Given this list of marker genes LSM7, LSM5, LSM4, LSM2, LSM8, LSM3, LSM6, here is a description of the gene set: A heteroheptameric, nuclear protein complex composed of Lsm2, Lsm3, Lsm4, Lsm5, Lsm6, Lsm7, and Lsm8, or orthologs thereof, that selectively binds to snRNAs, in particular U6 or U6atac snRNAs, and also to unspliced transcripts localized within the nucleus. Human Gene Set: GOCC_LSM2_8_COMPLEX studied in species Homo sapiens